Given this list of marker genes ITGB4, PLEC, LAMC1 (laminin subunit gamma 1), COL17A1, LAMA3 (NCBI Gene Id 3909), DST, here is a description of the gene set: Human Gene Set: GOBP_HEMIDESMOSOME_ASSEMBLY studied in species Homo sapiens Assembly of hemidesmosomes, integrin-containing protein complexes that bind to laminin in the basal lamina. Hemidesmosomes form the contact between the basal surface of epithelial cells and the underlying basal lamina.